Given this list of marker genes Cbr3, Nqo1, Aifm2, Ndufs8, Akr1c14, Dcxr (dicarbonyl L-xylulose reductase), Akr1c21, Ndufs2 (NCBI Gene Id 98507), mt-Nd4, Ndufv2, mt-Nd3, mt-Nd4l, Ndufs7, mt-Nd6, Ndufv1, Akr1c20, Nqo2, mt-Nd1, Ndufa2, Rtn4ip1, Akr1c19, Dhrs4, Cbr4, Ndufa10, Akr1c6, mt-Nd2, Akr1c18, Ndufs1, Cryz, Akr1c12, mt-Nd5, Akr1c13, Ndufs3, Adh4, Akr1cl, Ndufs4, Cbr1b, Cbr1 (carbonyl reductase 1), Ndufb7, here is a description of the gene set: Mouse Gene Set: GOMF_OXIDOREDUCTASE_ACTIVITY_ACTING_ON_NAD_P_H_QUINONE_OR_SIMILAR_COMPOUND_AS_ACCEPTOR Catalysis of an oxidation-reduction (redox) reaction in which NADH or NADPH acts as a hydrogen or electron donor and reduces a quinone or a similar acceptor molecule. species: Mus musculus